The following is a description of a gene set: Human Gene Set: SCIBETTA_KDM5B_TARGETS_DN from publication Scibetta AG, Santangelo S, Coleman J, Hall D, Chaplin T, Copier J, Catchpole S, Burchell J, Taylor-Papadimitriou J (PMID 17709396) Genes down-regulated in HB2 cells (mammary epithelium) upon expression of KDM5B off an adenoviral vector. The PLU-1/JARID1B nuclear protein, which is upregulated in breast cancers, belongs to the ARID family of DNA binding proteins and has strong transcriptional repression activity. To identify the target genes regulated by PLU-1/JARID1B, we overexpressed or silenced the human PLU-1/JARID1B gene in human mammary epithelial cells by using adenovirus and RNA interference systems, respectively, and then applied microarray analysis to identify candidate genes. A total of genes showed inversely correlated differential expression in the two systems. Most of the candidate genes were downregulated by the overexpression of PLU-1/JARID1B, including the MT genes, the tumor suppressor gene BRCA1, and genes involved in the regulation of the M phase of the mitotic cell cycle. Chromatin immunoprecipitation assays confirmed that the metallothionein 1H (MT1H), -1F, and -1X genes are direct transcriptional targets of PLU-1/JARID1B in vivo. Furthermore, the level of trimethyl H3K4 of the MT1H promoter was increased following silencing of PLU-1/JARID1B. Both the PLU-1/JARID1B protein and the ARID domain selectively bound CG-rich DNA. The GCACA/C motif, which is abundant in metallothionein promoters, was identified as a consensus binding sequence of the PLU-1/JARID1B ARID domain. As expected from the microarray data, cells overexpressing PLU-1/JARID1B have an impaired G(2)/M checkpoint. Our study provides insight into the molecular function of the breast cancer-associated transcriptional repressor PLU-1/JARID1B. studied in species Homo sapiens, and this is the list of marker genes: HMMR, STRN, NCAPH, SERINC5, PIR, UBR7, IVNS1ABP, GCA, SMARCA2, HACD1 (3-hydroxyacyl-CoA dehydratase 1), SCNN1A, FHL1, SKP2, SNRPG, EIF5B, BUB1B, NMB, DPY19L1 (NCBI Gene Id 23333), EPB41L1, SNRPD1, TUBB, PSIP1, SPTSSA, SWAP70, HSD17B8, PPOX, BUB3, LIMCH1, PLS3, OIP5 (Opa interacting protein 5), CDCA3, RAB3GAP2, AP4S1, AURKA, MT1H, MT1F, ASF1A, KDM5B, SMC5, PHF20, FBXO5, INSIG1, PRPS1, CYB5A, NEDD9, TOP2A, GAL, ISG15, CCNB1, DLGAP5, ITGB1BP1 (NCBI Gene Id 9270), DHCR24, MT1X, NDC80, CDK1, ARL6IP5, PSD3, REEP1, PDE3B, PBK, RECQL, FJX1, SS18, TMEM14A, KIF2C, NOL3, LRCH4, CAV1, TTK, LGALS3BP, ECT2, JADE2, BRCA1, FABP5, IPP, TNFSF13, SOX9, IGFBP2, PSME3